Given this list of marker genes SCNN1A, CYP2B6, KRT18, MLPH, ESR1, INPP4B, SLC7A8, MAGED2, ERBB4, FBP1, MAPT, GREB1, NUMA1 (nuclear mitotic apparatus protein 1), TBC1D9, KDM4B, SCUBE2, GATA3, CA12, WFS1, KIAA0232, XBP1, LRBA, KCNK15, TFF1, WWP1, ABAT, GSTM3, NAT1, ANXA9, P4HTM, CIRBP, TFF3, BBS4, APBB2, TNS2, AHNAK, here is a description of the gene set: About 70-80% of breast cancers express estrogen receptor alpha (ER-alpha), and estrogens play important roles in the development and growth of hormone-dependent tumors. Together with lymph node metastasis, tumor size, and histological grade, ER status is considered as one of the prognostic factors in breast cancer, and an indicator for hormonal treatment. To investigate genes and pathways that are associated with ER status and epithelial cells in breast tumor, we applied laser capture microdissection (LCM) technology to capture epithelial tumor cells from 28 lymph node-negative breast tumor samples, in which 17 patients had ER-alpha+ tumors, and 11 patients have ER-alpha- tumors. Gene expression profiles were analysed on Affymetrix Hu133A GeneChip. Meanwhile, gene profiles using total RNA isolated from bulk tumors of the same 28 patients were also generated. In total, genes and genes with significant P-value and having significant differential expression between ER-alpha+ and ER-alpha- tumors were identified from the LCM data set and bulk tissue data set, respectively. A total of genes were found to be common in both data sets, while genes were unique to the LCM data set and genes were present only in the bulk tumor data set. Pathway analysis with the genes using Gene Ontology suggested that genes involved in endocytosis, ceramide generation, Ras/ERK/Ark cascade, and JAT-STAT pathways may play roles related to ER. The gene profiling with LCM-captured tumor cells provides a unique approach to study epithelial tumor cells and to gain an insight into signaling pathways associated with ER. Human Gene Set: YANG_BREAST_CANCER_ESR1_UP species: Homo sapiens from publication Yang F, Foekens JA, Yu J, Sieuwerts AM, Timmermans M, Klijn JG, Atkins D, Wang Y, Jiang Y (PMID 16261164) Genes up-regulated in early primary breast tumors expressing ESR1 vs the ESR1 negative ones.